Given this list of marker genes Nrip1 (nuclear receptor interacting protein 1), Irs4, Socs1, Mixl1, Pck1, Mef2a, Osm, Irs3, Klf5, Ncoa2, Gdf10, Bmp4, Agrp, Stat6, Twist1, Gadd45a, Tle3, Foxo1, Nsg1, Cebpd, Pck2, Nampt, Wwtr1, Dvl1, Ins2, Stat5b, Wnt5b, Nr2f1, Agt, Nr1h3, Bmp3, Tgfb1, Lmna (lamin A), Cyp26a1, Ins1, Mef2d (NCBI Gene Id 99483), Bscl2, E2f4, Mbnl1, Rbl1, Lifr, Stat1, Il6st, Irs2, Igf1, Lpin3, Cebpb, Ppara, Ddit3, Stat5a, Stat2, Stat3, E2f1, Ndn, Gata4, Cntfr, Irs1, Tnf (NCBI Gene Id 21926), Pnpla3, Ppard, Ncoa1, Zmpste24, Celf1, Hnf1a, Agpat2, Rb1, Fas, Fzd1, Mef2b, Wnt1, Hmga1, Egr2, Ucp1, Epas1, Fabp4, Mef2c, Slc2a4, Lif (NCBI Gene Id 16878), Cisd1, Ahr, Dlk1, Gadd45b, Hif1a, Ncor1, Retn (resistin), Bmp1, Lpin1, Ctnnb1, Rora, Gh (NCBI Gene Id 14599), Rxrg, Ncor2, Adipoq, Id3, Socs3, Lipe, Plin1, Sp1, Pparg, Frzb (frizzled-related protein), Gata2, Cyp26b1, Rbl2, Creb1, Foxc2, Scd1, Trib3, Plin2, Gata3, Mif, Rara, Nr3c1, Smad3, Bmp2, Spock1, Serpine1, Lpl, Wnt10b, Lpin2, Ppargc1a, Lep, Cfd (NCBI Gene Id 11537), Cebpa, Klf15, Klf7, Klf6, Rxra, Sfrp4, Prlr, Srebf1, Ebf1, Il6, here is a description of the gene set: Mouse Gene Set: WP_ADIPOGENESIS_GENES Adipogenesis genes studied in species Mus musculus